The following is a description of a gene set: Reactome Pathway: Free fatty acid receptors species: Mus musculus This event has been computationally inferred from an event that has been demonstrated in another species.<p>The inference is based on the homology mapping from PANTHER. Briefly, reactions for which all involved PhysicalEntities (in input, output and catalyst) have a mapped orthologue/paralogue (for complexes at least 75% of components must have a mapping) are inferred to the other species. part of: Class A/1 (Rhodopsin-like receptors) electronically inferred by orthology from the curated human pathway, and this is the list of marker genes: Ffar2, Ffar3, Ffar1